The following is a description of a gene set: A developmental defect characterized by reduced length of the first metacarpal (long bone) of the hand. species: Homo sapiens Human Gene Set: HP_SHORT_1ST_METACARPAL Short 1st metacarpal, and this is the list of marker genes: DLK1, SMC3 (NCBI Gene Id 9126), SMC1A, PCNT, HDAC8, VPS35L (NCBI Gene Id 57020), HOXA13, RTL1, NOG, TAF6, NIPBL, CANT1, SOX9, RAD21, SALL4, ACVR1, LAMA5 (laminin subunit alpha 5), SRCAP (NCBI Gene Id 10847), GDF5, SETBP1, TBX5, FANCI, MEG3, SF3B4, BMPR1B, BRD4, ROBO1, FZD2